The following is a description of a gene set: Combining with a trace amine to initiate a change in cell activity. Trace amines are biogenic amines that are synthesized from aromatic amino acids and are substrates for monoamine oxidase, and are therefore detectable only at trace levels in mammals. studied in species Homo sapiens Human Gene Set: GOMF_TRACE_AMINE_RECEPTOR_ACTIVITY, and this is the list of marker genes: TAAR9, TAAR5, TAAR3P, TAAR6, TAAR1, TAAR8, TAAR2, OR5AN1